Given this list of marker genes SLX1A, SLX4, RECQL4, WRN, TERF2, BLM (BLM RecQ like helicase), SLX1B, XRCC3, RTEL1, POT1, TERF1, here is a description of the gene set: Human Gene Set: GOBP_TELOMERIC_LOOP_DISASSEMBLY species: Homo sapiens The telomere maintenance process in which telomeric loops are disassembled to permit efficient telomere replication.